Given this list of marker genes SLITRK1, DGKD, ZBTB40, ZNF431, ALPK3, KLHL29, SH3D21, ATP8A2, HEATR9, ALDH18A1, FBXO16, TET2, MYRIP, SCIMP, ZKSCAN2, AP3B2, HSP90AB1, PSG4, GAB4, PCNP, DMGDH, KCTD15, RFX7, INF2, SRA1, SMURF1, NCDN, ZDHHC18, RBFOX2, ITGA11, MARK2, BYSL, PTGES, ZNF385B, CD82, LMX1A, RARG, RARA, GPRIN1, CTSO, COX19, PITPNM3, SAMD4B, DCAF5, TBL1XR1, TEX264, C10orf105, UBE2I, PARP9, MRPS2, ASCC1, TNRC6B, DYRK1B (NCBI Gene Id 9149), TIAM1-AS1, KPNA1 (NCBI Gene Id 3836), ESAM, CDKN1A, CSMD2, GPR153, ACP2, LINC03040, TXLNA, LINC03034, PTAR1, THBS3, COTL1, SMCR8, GALNT13, HOXB5, BCL2L1, SCRT2, JAG1, DDA1 (DET1 and DDB1 associated 1), LY6G6C, RNASEL, COQ4, SRR, KCNH8, here is a description of the gene set: Human Gene Set: MIR6827_5P from publication Chen Y, Wang X (PMID 31504780) species: Homo sapiens Genes predicted to be targets of miRBase v22 microRNA hsa-miR-6827-5p in miRDB v6.0 with MirTarget v4 prediction scores > 80 (high confidence targets).